Given this list of marker genes Rab26, Tmed2, Selp, Atp8b5, Lamp3, Abhd2, Tmem63b, Cfap65, Rab6a, Fam170b, Rnd2, Snca, Hyal3, Cav1, Atp8a1, Syt4, Slc18b1, Moxd1 (monooxygenase, DBH-like 1), Dcst1, Kif1a, Pcsk4, Rab5a, Bsg, Syt2, Ace3, Zg16, Slc30a5, Izumo1, Trip11, Ccdc136 (coiled-coil domain containing 136), Slc18a2, Tmem225, Cyb561, Tcirg1 (NCBI Gene Id 27060), Rab27b, Pam, Vamp2, Vamp8, Eqtn, Syt1, Anxa7, Aqp1, Ica1, Scamp1, Acrbp, Spata31, Atp8b3, Abca3, Pnliprp2, Vps13b, Moxd2, Cuzd1, Creb3l4, Sparc, Spaca6, Slc30a2, Pkdrej, Sri, Exoc3, Actn1, Cav2, Vamp1, Flot2, Scg3, Abca12, Slc9a4, Cpe, Cadps, Slc2a3, Itpr1, Tex101, Zpbp, Itpr2 (inositol 1,4,5-triphosphate receptor 2), Kcnq1, Mfge8, Dcst2, Anxa4, Stxbp5, Abcc4, Adam8, Car4, Cd46, Slc30a8, Dnajc5, Spaca1, Zp3r, Spaca3 (NCBI Gene Id 75622), Syt5, Usp8, Sun1, Spaca4, Pla1a, Sycn, Lamp2, Slc18a1, Slc11a1, Vps13c, Serpina5, Ptprn2, Dmbt1, Dbh, Tmem184a, Itpr3, Tmem190, Glipr1l1, Slc17a9, Gp2 (glycoprotein 2 zymogen granule membrane), Tekt3, Tmem95, Hyal5, Clca1, Izumo3, Ift88, Stx3, Stxbp2, Cd177, Cylc1, Tmed10, here is a description of the gene set: Mouse Gene Set: GOCC_SECRETORY_GRANULE_MEMBRANE species: Mus musculus The lipid bilayer surrounding a secretory granule.